Given this list of marker genes IFNW1 (interferon omega 1), NSD2, IFNA8, PLCG2, IFNA2, HMCES, SLC15A4, SHLD1, BCL3, LIG4, MSH2, LGALS8, BATF, LFNG, DDRGK1, MAD2L2, CD180, ITFG2, HSPD1, MSH6, PHF14, EXO1, UNG, TLR4, CD28, IFNB1, ITM2A, GPR183, IFNA7 (interferon alpha 7), IFNA4, SHLD2, SPI1, POU2AF1, XBP1, DOCK11 (dedicator of cytokinesis 11), IL27RA, NKX2-3, IRF8, IFNA14, ADAM10, MLH1, IL21, IFNE, PMS2, ABL1, PARP3, TBX21, PAXIP1, EXOSC6, TAOK3, IFNA6, PLCL2, NBN, EXOSC3, AICDA, RNF8, IFNA21, GAPT, IFNK, CD19, NDFIP1, RAG2, IL2, RNF168, SUPT6H, SHLD3, LGALS1, IL4, IL6, CLCF1, TGFB1, CD40, IFNA17 (interferon alpha 17), IFNA1, CR1, BCL6, IFNA10, KMT5C, IL10, ERCC1, TNFSF4 (NCBI Gene Id 7292), ATAD5, IFNA16, NOTCH2, TNFSF13, CCR6, DLL1, RIF1, TP53BP1, ST3GAL1 (NCBI Gene Id 6482), NFKBIZ, ADA, SANBR, DOCK10, PTK2B, PCYT1A, KMT5B, FOXP3, APLF, SWAP70, FCGR2B, TFRC, STAT6, CD40LG, PTPRC, CDH17 (cadherin 17), C17orf99, MFNG, IFNA5, here is a description of the gene set: Human Gene Set: GOBP_B_CELL_ACTIVATION_INVOLVED_IN_IMMUNE_RESPONSE The change in morphology and behavior of a mature or immature B cell during an immune response, resulting from exposure to a mitogen, cytokine, chemokine, cellular ligand, or an antigen for which it is specific. studied in species Homo sapiens